The following is a description of a gene set: Human Gene Set: HE_LIM_SUN_FETAL_LUNG_C4_ILC3_CELL from publication He P, Lim K, Sun D, Pett JP, Jeng Q, Polanski K, Dong Z, Bolt L, Richardson L, Mamanova L, Dabrowska M, Wilbrey-Clark A, Madissoon E, Tuong ZK, Dann E, Suo C, Goh I, Yoshida M, Nikolić MZ, Janes SM, He X, Barker RA, Teichmann SA, Marioni JC, Meyer KB, Rawlins EL (PMID 36493756) species: Homo sapiens ILC3, and this is the list of marker genes: REEP3, CPNE7, TSPAN15, SPATS2L, TOX2, ANKH, GPR35, KRT86, ROGDI, RUNX2, LST1, PLXND1 (NCBI Gene Id 23652), MAEA, ADAM19, CXCR6, DPP4, RARG, CSF1, RGS16, KLF4, PRNP, SVIL, ARL3, GGT1, CDKN1A (cyclin dependent kinase inhibitor 1A), ATP10D, ABHD15 (NCBI Gene Id 116236), SLAMF1, FYCO1, APP, TIAM1, SLC4A10, IL17RE, SCART1, WDR86, GPR25, TNFSF13B, TTC39C-AS1, RORC, CCR6, LDLRAD4, REC8, SLC16A3, ADAM12, NR1D1, MVB12B, DAPK1, MAGED1, CD82, MPZL3, CAPG, MAN1A1, STK24, AFF3, JAML, ARHGAP10, IL23R, BLK, LZTFL1, CA2, MATN2, JMY, KIT, FSD1, AHR, NFATC1, PHACTR2, PERP, ENPP1, MGAT5, NRIP1, IL4I1